Given this list of marker genes LBR, NSDHL, HYLS1 (NCBI Gene Id 50957, HYLS1 centriolar and ciliogenesis associated), SLC26A2, COL2A1, CEP55, ZMPSTE24, SLC35D1, CENPF, GRIP1, TRIP11, CEP120, IL6ST, OSTM1, CALCRL, MUSK, PTH1R, LGI4, FLNB, ESCO2, RMND1, GBA1, COL11A1, FLNA, POR, ALPL, PITX1, WT1 (WT1 transcription factor), GDF5, NEK8, PHGDH, RNU4ATAC, here is a description of the gene set: studied in species Homo sapiens Human Gene Set: HP_STILLBIRTH Death of the fetus in utero after at least 22 weeks of gestation. Stillbirth